The following is a description of a gene set: The directed movement of a vesicle along a cytoskeletal fiber such as a microtubule or and actin filament, mediated by motor proteins. Human Gene Set: GOBP_VESICLE_CYTOSKELETAL_TRAFFICKING species: Homo sapiens, and this is the list of marker genes: DTNBP1, MAP2K1, AP3S2, AP3B1, BLOC1S3 (NCBI Gene Id 388552), F8A3, KIF28P, SYT4, KIF5B, KIFAP3, NDE1, DYNC1I1, HAP1, BLOC1S6, PPFIA2, AP3B2, BLOC1S4, NDEL1, SPG11, MYO1C, BLOC1S5, RASGRP1, FBXW11, AP3M2, MAP2, AP3D1, BORCS5, KIF3B, BICDL1, F8A1, KIF5A, ACTN4, KIF1C, KIF16B, KIF1B, CDR2L (NCBI Gene Id 30850), AP3M1, PAFAH1B1, MYO5A, FNBP1L, BICDL2, STK11 (serine/threonine kinase 11), CLN3, FYCO1, HTT, F8A2 (NCBI Gene Id 474383), KIF1A, WASL, SYBU, KIF13A, TRAK2, AP3S1, BLOC1S1, TANC2, SNAPIN, KIF3A, CCDC186, BLOC1S2, RAB1A, TRIM46, TRAK1